The following is a description of a gene set: Mouse Gene Set: GOBP_MULTIVESICULAR_BODY_LYSOSOME_FUSION species: Mus musculus The organelle membrane fusion process in which the membrane of a multivesicular body fuses with a lysosome to create a hybrid organelle., and this is the list of marker genes: Chmp1b2, Chmp3, Chmp2a, Chmp7, Chmp2b, Chmp5, Chmp4c, Chmp1a, Chmp6, Chmp4b, Chmp1b (charged multivesicular body protein 1B), Rufy4